Given this list of marker genes Slc2a3, Slc23a2, Gsto2, Gsto1, Slc23a1, Cyb5a, Cyb5r3, Slc2a1, here is a description of the gene set: Vitamin C (ascorbate) metabolism Mouse Gene Set: REACTOME_VITAMIN_C_ASCORBATE_METABOLISM studied in species Mus musculus